Given this list of marker genes Synm, Actn3, Myh7, Atp2a1, Strit1, Mylk2, Tnnt1, here is a description of the gene set: Mouse Gene Set: GOBP_VOLUNTARY_SKELETAL_MUSCLE_CONTRACTION studied in species Mus musculus A process in which force is generated within voluntary skeletal muscle tissue, resulting in a change in muscle geometry. Force generation involves a chemo-mechanical energy conversion step that is carried out by the actin/myosin complex activity, which generates force through ATP hydrolysis. In the voluntary skeletal muscle, the muscle contraction takes advantage of an ordered sarcomeric structure and it is under voluntary control. Voluntary skeletal muscle is skeletal muscle that is under conscious control.